The following is a description of a gene set: The process whose specific outcome is the progression of the trigeminal nerve over time, from its formation to the mature structure. The trigeminal nerve is composed of three large branches. They are the ophthalmic (V1, sensory), maxillary (V2, sensory) and mandibular (V3, motor and sensory) branches. The sensory ophthalmic branch travels through the superior orbital fissure and passes through the orbit to reach the skin of the forehead and top of the head. The maxillary nerve contains sensory branches that reach the pterygopalatine fossa via the inferior orbital fissure (face, cheek and upper teeth) and pterygopalatine canal (soft and hard palate, nasal cavity and pharynx). The motor part of the mandibular branch is distributed to the muscles of mastication, the mylohyoid muscle and the anterior belly of the digastric. The mandibular nerve also innervates the tensor veli palatini and tensor tympani muscles. The sensory part of the mandibular nerve is composed of branches that carry general sensory information from the mucous membranes of the mouth and cheek, anterior two-thirds of the tongue, lower teeth, skin of the lower jaw, side of the head and scalp and meninges of the anterior and middle cranial fossae. studied in species Homo sapiens Human Gene Set: GOBP_TRIGEMINAL_NERVE_DEVELOPMENT, and this is the list of marker genes: DRGX, SEMA3F, POU4F1, TFAP2A, PLXNA3, TIFAB (TIFA inhibitor), NEUROG1, ISL1, NRP2, SEMA3A, PLXNA4, NRP1, DCANP1